Given this list of marker genes SMC2, PCLAF, DUT, TOP2A, TMEM106C, BIRC5, PTTG1, HMGB2 (high mobility group box 2), GGH, MKI67, CDKN3, DTYMK (NCBI Gene Id 9102), TUBB, CENPF, KPNA2, TMPO, H2AZ1, NUSAP1, MCM7, RPA3, HMGN2, CKS1B, CDK1, TYMS, DEK, TUBB4B, TK1, IDH2, NUCKS1 (nuclear casein kinase and cyclin dependent kinase substrate 1), CARHSP1, SKA2, HMGB1, H4C3, ANP32E, HMGB3, RANBP1 (RAN binding protein 1), H2AZ2, CENPM, CKS2 (CDC28 protein kinase regulatory subunit 2), PCNA (NCBI Gene Id 5111), DNMT1, SMC4, UBE2C, STMN1, TUBA1B, CENPW, ZWINT, here is a description of the gene set: In this study, an extensive analysis was conducted to define meta-programs (MPs) capturing intra-tumor heterogeneity across a spectrum of tumor types. The approach utilized non-negative matrix factorization (NMF) to analyze each cell type separately within individual tumor samples. This involved the analysis of malignant cells, macrophages, fibroblasts, endothelial cells, epithelial cells, T-cells, and B-cells. NMF was executed with varying parameter values (K=4, 5, 6, 7, 8, 9), thereby generating 39 programs for each cell type per sample. Each NMF program was summarized by the top genes based on NMF coefficients.\nRobust MPs were then delineated for each cell type using a set of stringent criteria, including recurrence within the same tumor, similarity to programs in other tumors, and non-redundancy within a tumor. Subsequently, these robust NMF programs were clustered (per cell type) based on Jaccard similarity, leading to the identification of MPs associated with each cell type.\nTo enhance the quality of the MPs, a refinement steps were undertaken, involving the removal of MPs suspected of reflecting low-quality data (with an overrepresentation of ribosomal proteins or mitochondrial-encoded genes), single-study inclusion, or similarity to miss-annotated cell types. species: Homo sapiens Human Gene Set: GAVISH_3CA_METAPROGRAM_MACROPHAGES_CELL_CYCLE from publication Gavish A, Tyler M, Greenwald AC, Hoefflin R, Simkin D, Tschernichovsky R, Galili Darnell N, Somech E, Barbolin C, Antman T, Kovarsky D, Barrett T, Gonzalez Castro LN, Halder D, Chanoch-Myers R, Laffy J, Mints M, Wider A, Tal R, Spitzer A, Hara T, Raitses-Gurevich M, Stossel C, Golan T, Tirosh A, Suvà ML, Puram SV, Tirosh I (PMID 37258682) Genes upregulated in subsets of cells of a given type within various tumors